Given this list of marker genes Igdcc3, Agpat3, Ptpn4, Xaf1, Slc19a1, Col6a2, Calm3, Lin54, Pcdh9, Apol7b, Nrip2, Zfhx3, Fat3, Zbtb47, Smc1a, Fndc5, Ctc1, Fut8, Tmem170b, Ndst2, Hc (NCBI Gene Id 15139), Nr1h2, Klf12, Prox1, Szrd1, Drp2, Qrsl1, Sbk1, Llgl1, Mapkbp1, Apol7e, App, Irak1bp1, Zmym2 (zinc finger, MYM-type 2), Ssbp2, Spry2, Ntsr1, Zfp696, Septin6, Nifk, Snai3, Zfp354c, Fjx1 (four jointed box 1), Pfkl, Kazn, Kcna5, Tmem132a, Cpped1, Cnga3 (NCBI Gene Id 12790), Bach1, here is a description of the gene set: Mouse Gene Set: MIR_7653_5P Genes predicted to be targets of miRBase v22 microRNA mmu_miR_7653_5p in miRDB v6.0 with MirTarget v4 prediction scores > 80 (high confidence targets). from publication Chen Y, Wang X (PMID 31504780) species: Mus musculus